The following is a description of a gene set: Electron-dense organelle with a granular internal matrix; contains proteins destined to be secreted. studied in species Mus musculus Mouse Gene Set: GOCC_DENSE_CORE_GRANULE, and this is the list of marker genes: Npy1r, Htr1d, Syt13, Sod1, Syt2, Gnai2, Oprd1, Syt4, Dvl1, Bace2, Pdyn, Stxbp5, Adrb1, Bdnf, Npff (neuropeptide FF-amide peptide precursor), Actn1, Ncs1, Slc6a9, Syt5, Grp, Vps13c, Penk, Spx, Cadps, P2rx2, Sst, Npy, Syt9, Crh, Avp, Slc6a5, Adrb2, Oxt, Slc18a2, Plat, Hcrt, Syt8, Ghrl, Syt7, Adam8, Vps13a, Igf1, Plcb2, Ecrg4, Syt1, Scg2, Stxbp5l (NCBI Gene Id 207227), Dmxl2, App, Kif1a, Chga (NCBI Gene Id 12652), Fzd8, Crhbp, Adcyap1, Myrip, Aqp1, Cpe, Cacna2d1, Calcrl, Calca